Given this list of marker genes Fos, H1f2, Klf2, Cr2, Fcer2a, here is a description of the gene set: Genes negatively differentially expressed in cell type: B cell upon treatment with cytokine: IFN-κ in mouse lymph nodes in vivo. from publication Cui A, Huang T, Li S, Ma A, Pérez JL, Sander C, Keskin DB, Wu CJ, Fraenkel E, Hacohen N (PMID 38057668) studied in species Mus musculus Mouse Gene Set: CUI_B_CELL_IFNK_RESPONSE_DN Cytokines mediate cell-cell communication in the immune system and represent important therapeutic targets. A myriad of studies have highlighted their central role in immune function, yet we lack a global view of the cellular responses of each immune cell type to each cytokine. To address this gap, the authors created the Immune Dictionary, a compendium of single-cell transcriptomic profiles of more than 17 immune cell types in response to each of 86 cytokines (>1,400 cytokine-cell type combinations) in mouse lymph nodes in vivo. A cytokine-centric view of the dictionary revealed that most cytokines induce highly cell-type-specific responses. For example, the inflammatory cytokine interleukin-1β induces distinct gene programmes in almost every cell type. A cell-type-centric view of the dictionary identified more than 66 cytokine-driven cellular polarization states across immune cell types, including previously uncharacterized states such as an interleukin-18-induced polyfunctional natural killer cell state.